Given this list of marker genes Srp54c, Tram1l1, Sec61a2, Sec61a1, Srp54a, Tram1, Sec61b, Zfand2b, Tram2, here is a description of the gene set: studied in species Mus musculus Mouse Gene Set: GOBP_SRP_DEPENDENT_COTRANSLATIONAL_PROTEIN_TARGETING_TO_MEMBRANE_TRANSLOCATION The process during cotranslational membrane targeting wherein proteins move across a membrane. SRP and its receptor initiate the transfer of the nascent chain across the endoplasmic reticulum (ER) membrane; they then dissociate from the chain, which is transferred to a set of transmembrane proteins, collectively called the translocon. Once the nascent chain translocon complex is assembled, the elongating chain passes directly from the large ribosomal subunit into the centers of the translocon, a protein-lined channel within the membrane. The growing chain is never exposed to the cytosol and does not fold until it reaches the ER lumen.